The following is a description of a gene set: The pronucleus originating from the spermatozoa that was involved in fertilization. Mouse Gene Set: GOCC_MALE_PRONUCLEUS species: Mus musculus, and this is the list of marker genes: Tbp, Rif1, Mettl23, Cbx1, Tet3, Stpg4, Ccna2, Dppa3